Given this list of marker genes Casp8, Fadd, here is a description of the gene set: electronically inferred by orthology from the curated human pathway Reactome Pathway: TRAIL  signaling This event has been computationally inferred from an event that has been demonstrated in another species.<p>The inference is based on the homology mapping from PANTHER. Briefly, reactions for which all involved PhysicalEntities (in input, output and catalyst) have a mapped orthologue/paralogue (for complexes at least 75% of components must have a mapping) are inferred to the other species. part of: Death Receptor Signaling species: Mus musculus